The following is a description of a gene set: Human Gene Set: CCCAGAG_MIR326 Genes having at least one occurence of the motif CCCAGAG in their 3' untranslated region. The motif represents putative target (that is, seed match) of human mature miRNA hsa-miR-326 (v7.1 miRBase). species: Homo sapiens, and this is the list of marker genes: PTK7, SEC63, RPS6KA3, PHLPP2, SAMD4B, DUSP15, OGT, TCF4, COPS7A, LRRTM1, ATXN1, CIC, NLK, SLC4A5, SLC8A2, BRPF3, ARPP21, EPN2, DAG1, RUNX3, SNCB, VPS39, METAP1, ST8SIA2, DRD3, MIR600HG, OXSR1 (NCBI Gene Id 9943), SPMIP6, RPS6KA1, PPP1R3F, CRHR1, VLDLR, CAGE1, PALM, PAPPA, EHMT2, PABPC1L2A, RASSF1, ACRBP, GGT7, YBX2, PAX8, TBL1XR1, EYA3 (NCBI Gene Id 2140), ADGRG2, ITSN1, FDX2, GNAO1, PTGDS, ACACA, BCL2L1, SUGP1, INAVA, SMAD6, EML2, CDH22, CEP85, WHRN, CYP1B1-AS1, RPGR, ZMIZ1, MIEF2, RARG, RIMS4, RHOT1, PIP4K2C, RAP2A, ZNF609, RASL10B, BSDC1 (BSD domain containing 1), CTCF, KLHL14, PURG, KIAA0513, CSNK1G3, H6PD, TSPAN14, NCKIPSD, OTP, AUP1, SPRYD3, SYNGAP1, TFAP4, FAM53C, HTR2C, SCARF1, SSH2, PKIA, UBE2O, EGLN2, FAIM2 (NCBI Gene Id 26294), NAV3, CACNA1E, FNDC3A, CDK2AP1, DRD2, NCALD, ATP2B2, HNRNPA2B1, BCL11B, LRRC32, NRP1, AHCYL2, BTBD3, AGPAT4, ZBTB7B, SEMA6D, ANKFY1, METTL15, SLC27A4, LIMK1, DLGAP2, PPP4R1 (protein phosphatase 4 regulatory subunit 1), IGF2BP1, CELF2, CRIM1, EPHB3, CNBP, EGR4, ST3GAL3, KCTD15, RTL6, GPI, KCNIP2, SPOCK1, CEBPA, SOX12, FBXL20, PPP3CB, RALGAPA1 (Ral GTPase activating protein catalytic subunit alpha 1), UBE2J2, SRPRA, ELK1, ERG28 (NCBI Gene Id 11161), PPP1R9B, ATP8B2, CORO2B, DBNDD2, EPHA8, GABBR2, UBXN10 (UBX domain protein 10), DIDO1, PPM1E, PLXNA2, TMEM127, TLN1, ADAMTS6, NHS, PXN (paxillin), ESRRA, CEP192, SLC38A3, PTCH1, MMP24, RALGPS2, RFLNB